Given this list of marker genes Cd3e, Cd28, Cd55b, Il20rb, Ctla4, Bmp4, Icosl, Sftpd, Cd244a, Tnfsf4, Cd274, Btla, Lgals9, Xcl1, Scrib, Tgfbr2, Tspan32, Spn, Cd81, Casp3 (caspase 3), Pla2g2f, Slc4a2, Pawr, Lmo1, Nck1, Il1b, Tnfsf13b, Il2, Irf1, Il3, Cd209a, Peli1, Ndfip1, Zap70, Stat5b, Cd6, Cd209e, Irgm1 (immunity-related GTPase family M member 1), Il6st, Btn2a2, Dlg1 (NCBI Gene Id 320792), H2-DMb2, Il1a, Card11, Il23a, Tnfrsf1b, Traf6, Znhit1, Pla2g5, Lilrb4b, Havcr2, Igfbp2, Rps3, Cd4 (CD4 antigen), Rc3h1, Ccl5, Cd59a, Jak3, Selenok, Syk, Vsig4, Ccdc88b, Ripk3, Mapk8ip1 (NCBI Gene Id 19099), Prkcq, Cd86, Slc7a1, Bid, Ager, Il2ra, Arg1, Il6 (NCBI Gene Id 16193), Arg2, Il27, Itch, Il15, Hes1, Rasal3, Ripk2, Scgb1a1, Cd209d, Clec4g, Il21, Gpnmb, Vtcn1, Cblb, Efnb1, Il12rb1, Cebpb, Igf1, Adk, Vsir, Sos2, Il4i1, Tnfrsf13c, Pnp, Cd80, Gpam, H2-Aa, Pla2g2d (NCBI Gene Id 18782), Crtam, Hmgb1, Ctnnb1, Cd276, Sh3rf1, Zbtb7b, Cd46, Ptpn22, Cd37, Tmem131l, Slfn1, Ifng, Cd40lg, Tfrc, Btnl2, Ccr7, Rac2, Sdc4, Cd209c, Epo, Prnp, Stat5a, Spta1, Tgfb1, Vcam1, Foxj1, Cd1d2, Ido1, Ptpn6, Carmil2, Laptm5, Mad1l1, Lep, H2-T23, Tnfrsf21, Ripor2, Pla2g2a, Cd44, Tnfsf18, Kitl, Lgals3, Tnfsf9, Zc3h12d, Bcl6, Pde5a, Pten, Il4, Ceacam1, Dnaja3, Cd55, Bmi1 (Bmi1 polycomb ring finger oncogene), Coro1a, H2-DMb1, Lilrb4a, Nr5a2, Twsg1, Pycard, Tyk2, Igf2, Blm, Ihh, Anxa1, Ptprc, Glmn, Nck2, Aif1, Tsc2, Il12b, Ppp3ca, Jak2, Dlg5, Zp3 (NCBI Gene Id 22788), Tarm1, Cdkn2a, Il12a, Sos1, Ccl19, Cd24a, Erbb2, Cd1d1, Tnfrsf9, Marchf7 (membrane associated ring-CH-type finger 7), Tnfrsf14, Pdcd1lg2, Itgal, Clec2i, Il18, Slc4a1, Slamf1, Sash3 (SAM and SH3 domain containing 3), Fadd, Ccr2, H2-M3, Gnrh1, Lrrc32, Cd59b (CD59b antigen), Prkar1a, Shh, Foxp3, Dhps, Nckap1l, here is a description of the gene set: studied in species Mus musculus Mouse Gene Set: GOBP_REGULATION_OF_T_CELL_PROLIFERATION Any process that modulates the frequency, rate or extent of T cell proliferation.